Given this list of marker genes CNTFR, IL6ST, IL11RA, JAK1, IL11, STAT3, IL6R, here is a description of the gene set: The series of molecular signals initiated by the binding of interleukin-11 to its receptor on the surface of a target cell, and ending with the regulation of a downstream cellular process, e.g. transcription. species: Homo sapiens Human Gene Set: GOBP_INTERLEUKIN_11_MEDIATED_SIGNALING_PATHWAY